Given this list of marker genes SULT1E1, CYP3A4, CYP19A1, HSD17B2, UGT2B7, HSD17B3, CYP2C9, HSD17B4, HSD17B1, HSD17B7, CYP1B1, CYP2C8, CYP3A5, COMT, HSD17B10, CYP1A2, HSD17B8, AKR1C3, UGT2A2, CYP2C19, HSD17B14, CYP3A7, UGT1A8, UGT1A10, here is a description of the gene set: species: Homo sapiens Estrogen metabolism Human Gene Set: WP_ESTROGEN_METABOLISM_WP5276